Given this list of marker genes Amhr2, Zwint, Mtch1, Prmt1 (NCBI Gene Id 80681), Prrx1, Inhba, Rflna, Fxyd6, Tgfbi, Gap43, Col8a1, Tuba4a, Tagln3, Pcdh8, Lypd1 (NCBI Gene Id 98472), Enc1, Syt4, Nuak1, Lix1, Tubb3, Hmx1, Elavl3, Olfm1, St3gal2, Elavl4, Spon2, Sumo3, Hspa8, Mxra7, Kpna2, Rasa3, Basp1, Hmga2, Tuba-rs1, Tuba1b, Nnat, Cxcl12, Crmp1, Nsg2, Klc1, Ntrk2, Plat, Chd3, Amph, Calcb (NCBI Gene Id 116903), Htr3b, Hic1, Rspo1, Stmn1, Rimkla, Tuba3a, Prph, Igfbp4, Calca, Gna14, here is a description of the gene set: Mouse Gene Set: SCHAEFFER_PROSTATE_DEVELOPMENT_12HR_DN species: Mus musculus from publication Schaeffer EM, Marchionni L, Huang Z, Simons B, Blackman A, Yu W, Parmigiani G, Berman DM (PMID 18794802) Cancer cells differentiate along specific lineages that largely determine their clinical and biologic behavior. Distinct cancer phenotypes from different cells and organs likely result from unique gene expression repertoires established in the embryo and maintained after malignant transformation. We used comprehensive gene expression analysis to examine this concept in the prostate, an organ with a tractable developmental program and a high propensity for cancer. We focused on gene expression in the murine prostate rudiment at three time points during the first 48 h of exposure to androgen, which initiates proliferation and invasion of prostate epithelial buds into surrounding urogenital sinus mesenchyme. Here, we show that androgen exposure regulates genes previously implicated in prostate carcinogenesis comprising pathways for the phosphatase and tensin homolog (PTEN), fibroblast growth factor (FGF)/mitogen-activated protein kinase (MAPK), and Wnt signaling along with cellular programs regulating such 'hallmarks' of cancer as angiogenesis, apoptosis, migration and proliferation. We found statistically significant evidence for novel androgen-induced gene regulation events that establish and/or maintain prostate cell fate. These include modulation of gene expression through microRNAs, expression of specific transcription factors, and regulation of their predicted targets. By querying public gene expression databases from other tissues, we found that rather than generally characterizing androgen exposure or epithelial budding, the early prostate development program more closely resembles the program for human prostate cancer. Most importantly, early androgen-regulated genes and functional themes associated with prostate development were highly enriched in contrasts between increasingly lethal forms of prostate cancer, confirming a 'reactivation' of embryonic pathways for proliferation and invasion in prostate cancer progression. Among the genes with the most significant links to the development and cancer, we highlight coordinate induction of the transcription factor Sox9 and suppression of the proapoptotic phospholipid-binding protein Annexin A1 that link early prostate development to early prostate carcinogenesis. These results credential early prostate development as a reliable and valid model system for the investigation of genes and pathways that drive prostate cancer. Genes down-regulated in the urogenital sinus (UGS) of day E16 females exposed to the androgen dihydrotestosterone for 12 h.